Given this list of marker genes Sirt4, 3110082I17Rik, Abca2, Crtc3, Trib3, Apoe, Klhl25, Ch25h, Idi2, Adra2a, Dcaf5, Pik3cg, Mup2, Ccnc, Pde3b, Dbi, Prkaa1, Gper1, Bscl2 (BSCL2 lipid droplet biogenesis associated, seipin), Insig1, Sorl1, Hcar2, Apoc2, Sirt1, Obp2a, Ormdl1, Fmo2, Il1b, Acacb, Gimap3, Wnt4, Pibf1, Snai2, Slc22a13, Tnf, Ceacam2 (NCBI Gene Id 26367), Fmc1, Ggcx, Brca1, Gimap5, Cnr1, Cdk8, Mup1, Mup3, Hcar1, Apoc1, Apoc3, Lpcat1, Slc27a1, Insig2, Ormdl2, Asxl3, Akr1c18, Rest, Akt1, Endou (NCBI Gene Id 19011), Alk, Ins1, Cidec, Sphk1, Cidea, Gpld1, Cyp27b1, Sik2, Pdgfa, Dkk3, Esr1 (NCBI Gene Id 13982), Mup5, Apod, Pdgfb, Mfsd2a, Mup11, Gfi1, Fgf15, Ubr4, Sod1, Ncor1 (nuclear receptor co-repressor 1), Bmp5, Mir214, Bmp2, Erlin2, Tmx1, Ins2, Wdtc1, Nr1h4, Acadl, Nr0b1, Snai1, Pde8b, Fmo4, Mup4, Fmo1, Prox1, Acadvl, Dkkl1, Malrd1, Appl2, Mir199a-2, Atg7 (NCBI Gene Id 74244), Apoc2l, Ormdl3, Serpina12, Srebf1, Nfkb1, Adora1, Sox9, Atp1a1, Ceacam1, Plin5, Cyp7a1, Sik1, Dgat2, Prmt3, Apobec1, Ccdc3, Erlin1, Apoa2, Hrh1, Etfbkmt, here is a description of the gene set: Mouse Gene Set: GOBP_NEGATIVE_REGULATION_OF_LIPID_METABOLIC_PROCESS Any process that stops, prevents, or reduces the frequency, rate or extent of the chemical reactions and pathways involving lipids. species: Mus musculus